Given this list of marker genes Mdga2, Arid4a, Arf6, Gm24474, Gm19047, Gm9887, Psma3, Rps29, Cdkl1, Gm18030, Gm19001, Gm32151, Mir681, Gm18113, Abhd12b, Gm2915, Hspe1-ps1, Gm7868, Gm24449, Map4k5, Gm18940 (predicted gene, 18940), 3110056K07Rik, Gm6316, Vcpkmt, Rpl17-ps3, Gm31447, Nemf, Klhdc1, Tomm20l, 5830428M24Rik, Gm3086, Timm9, Gm46355, 4930512B01Rik, Sos2 (NCBI Gene Id 20663), Klhdc2, Dnaaf2, Rpl36al, Tmx1 (NCBI Gene Id 72736), Dmac2l, Gm19144, Atl1, L2hgdh, Gm19221, Trim9, Sav1, Gm23826, Gm32219, Lrr1, F730035M05Rik, Gm20102, Gm40437, Gm17821, Gm7959, Gm15571, Gm32369, Pole2, Actr10, Gm2912, 9330151L19Rik (NCBI Gene Id 414085), Nin (ninein), Gm47290, Gm19176 (predicted gene, 19176), Gm26256, Rpl10l, Gm24499, Pygl, 2700049A03Rik, Gm10457, Frmd6, Mgat2, Gm19045, here is a description of the gene set: Mouse Gene Set: chr12C2 species: Mus musculus